Given this list of marker genes Nsmce2, Slf2, Ddx11, Sfpq, Bub1, Sgo2a, Fen1, Rad21, Slf1, Macroh2a1, Smc5, here is a description of the gene set: Any process that activates or increases the frequency, rate or extent of sister chromatid cohesion. Mouse Gene Set: GOBP_POSITIVE_REGULATION_OF_SISTER_CHROMATID_COHESION studied in species Mus musculus